The following is a description of a gene set: Effects of Neuromedin-U on gene expression in mouse D10.G4.1 T-cells natively expressing the GPCR Axor13 from publication Johnson EN, Appelbaum ER, Carpenter DC, Cox RF, Disa J, Foley JJ, Ghosh SK, Naselsky DP, Pullen MA, Sarau HM, Scheff SR, Steplewski KM, Zaks-Zilberman M, Aiyar N (PMID 15585845) Genes up-regulated in D10.G4.1 T cell line (12h): control versus treated with NMU. studied in species Homo sapiens Human Gene Set: GSE1791_CTRL_VS_NEUROMEDINU_IN_T_CELL_LINE_12H_UP, and this is the list of marker genes: SORT1, PELI2, BMAL1, PIP4K2A, TMEM14B, ANKS1B, HAGH, ZNF518B, HSD11B1, DCTN3 (NCBI Gene Id 11258), OTUD6B, KCNK6, ZNF765, HENMT1, RAB4A, LINC01019, COQ9, TMEM14C, PPP1R7, HADHA, CCT7, CD302, CNOT1, ANKMY2, CARD9, UBE2M, GGA3, FH, MRPL48, BTBD6, FBXO42, TMEM147, LRRC47, BLVRB, KISS1R, ST13, MAPKAPK5, TKT, CUTC, FLVCR2, TTC9C, DENND4C, PRPS1, C17orf58, IRF4, MCCC1, PRKCI (NCBI Gene Id 5584), TNFRSF18, RABEPK, SIGLEC17P, AGO2, DYRK2, APOO, CDK5, BZW2, CSE1L, ARMH3, ABL1, MCM9, PDGFC, SAYSD1, ALOX15, LUC7L2, TRAPPC12, HACD1, PKD1P6, MRPS7, ZFP36L1, RAD1, POLRMT, DDX18, EMB, DNAAF2, FCER2, ACAD9, SLC35D1, APMAP, XPO7, EEF2K, FAM89B, ACACA, COG2, AP2M1, KNSTRN, WDR24 (WD repeat domain 24), SLC26A6, NUDT16L2P, NUDCD2, GBA2, MAF, CERK, GUSB, LMNA, PSME3IP1, TSPAN33, MAOA, NOTCH3, SUCLA2, SNHG12, CLEC16A, PALLD, NUP85, EEPD1, TMEM71 (transmembrane protein 71), PARP1, INIP, PIK3CD, TAPT1, TRMT61B, SIRPA, UBAC2, BNIP3, PACS1, PPM1F, INTS10, ANKRD18A, CCSAP, TMEM123, GFOD3P, TNFRSF4, ZBED1, GAB3, ZBTB44, AKR1B1, SDF4, ADI1, NLRP11, FMNL3, TRIB2, MBTPS1, NSMCE3, GSTP1, ATP6V0D1, CYSLTR1, VEGFB, LEO1, ETV6, FAM110B, ZER1, PLOD1, NPIPA1, VPS26B, CHTF8, TUBG1, SNRNP25, CISH, SNRNP40, PCM1, NFXL1, CCL26, MIS18BP1, H2BC6, ZNF570, TMCO3 (transmembrane and coiled-coil domains 3), GMPR2, TTLL12, IDH3G, ECH1, BLTP2, ZZEF1, WIPI2, AQR, CHST7, APBB1IP, EPAS1, EIF2B1, MRRF, PRMT1, REEP5, SDHAP2, GAS2L3, WNT7A, HACD3, HADHB, WBP11, NDUFC2, GPI, PRKDC, SPINT2, AFG2B, NUP93, SLC47A1, MEN1, CTNNAL1, CHMP1B, ARL4C, POLR2J2, FCGRT, CAMK1D, GRK3, TCERG1, SRP14, CCL17, TUBGCP3 (NCBI Gene Id 10426), PIGH, BSG, GLIS2, WRNIP1 (WRN helicase interacting protein 1)